The following is a description of a gene set: With increasing age, the ability of the immune system to protect against recurring infections or to control chronic infections erodes. The objective of the current study was to identify gene expression signatures in elderly CD4 T cell responses studied in species Homo sapiens Genes up-regulated in comparison of untreated CD4 memory T cells from old donors versus those treated with TSST at 16 h. from publication Yu M, Li G, Lee WW, Yuan M, Cui D, Weyand CM, Goronzy JJ (PMID 22434910) Human Gene Set: GSE36476_CTRL_VS_TSST_ACT_16H_MEMORY_CD4_TCELL_OLD_UP, and this is the list of marker genes: RLF, SH3BGRL, SIK1, DBNDD1, ARHGEF6, ZBTB25, RASGRP2, TSC22D3, CD48, LIPC, FRAT1, TCL6, SIRPG, ARHGEF18, ITGB2, LAIR1, TENT5C, KRT75, THSD7A, PPP1CB, DAZAP2, PCBP3, ITM2A, ATF7IP2, CHI3L2, ARGLU1, NELL2, RALGAPA1, UVRAG, USP3, TMX4, NR5A1, PRKCB, GZMK, C4BPA, SSBP2, ANXA1, MMP15, ARL4C, OSER1, RIPOR2, KCNH2, PLCL2, VNN2, PTP4A1, RAP1GAP2, GSTK1, GABPB1-IT1, SIGIRR, DNAJB1, MGP, CIRBP (NCBI Gene Id 1153), SEMA3G, BEX3, SERINC5, MGAT4A, ADD3, FOS, MTCP1, CYP4F12, ZNF711, DOCK2, SPTBN1, TLR3, ELAPOR1, SETD2, CUTA, MYCBP2, FYB1, S100G, AQP3, PCF11, IQSEC1, OR1A1, QSER1, NME8, JOSD1, RPL23AP53, BNIP3L, LINC00588, LDB3, NDRG3, LEF1, SERPINB13 (NCBI Gene Id 54735), PDE4D, NLRP3, HHLA1, TXNIP, ELF2, ZNF226, AKAP7, ZNF331, TLE4, CBFA2T2, DNASE1L1, C11orf21, ZFP36L2, JUN, CLDN6 (NCBI Gene Id 9074), STX8 (NCBI Gene Id 9482), MARCHF8, SLC2A3, MRTFB, PITPNC1, PZP, TCEAL2, NUDT15, LONP2, GRIN1, SORL1, KANSL2, MXI1, MLLT11, ARL4A, S100A4, MCF2L, KLF2, GNB5, GABRB2, CYP11A1, SLC28A2, PIK3IP1, ITM2B, FAM8A1, TSPYL4, PBXIP1, CR2, TBC1D5, BAG5 (BAG cochaperone 5), CRYL1, ZFP36, RGL2, ZNF529, YPEL5, PXDN, HSD17B11, KCNK15-AS1, PPOX, TSPYL1 (NCBI Gene Id 7259), SLC17A3, NOMO3, IRS2, CKLF, ACACB, TNFAIP3, HECA, DGKD, FUT8, ACKR2, DPEP2, LILRA6, SMG7-AS1, TNNC2, H2AC25, ITGB1, NF1, KIF3C, EYA1 (EYA transcriptional coactivator and phosphatase 1), CD3D, CENPF (NCBI Gene Id 51468), AK1, NR3C2, SUN2, MSRA, HHAT, GNAO1, NUSAP1, IL11RA, NNMT, SAMHD1, MAX, KLHL3, RBM48, DLG5, MAPRE2, NFYA, BIN1, GPA33 (glycoprotein A33), PARP3, WNT7A, PLCG1, ENPP2, ZNF395, MNT, PDK1, TOB1, ADCY7, CHD1, PDZD8, TNIK, PIAS2, FCGRT, MOAP1, PRKCQ, DYRK2, PLCD1, NUCB2